The following is a description of a gene set: Human Gene Set: GOMF_RNA_POLYMERASE_II_CTD_HEPTAPEPTIDE_REPEAT_KINASE_ACTIVITY species: Homo sapiens Catalysis of the reaction: ATP + RNA polymerase II large subunit CTD heptapeptide repeat (consensus YSPTSPS) = ADP + H+ + phosphorylated RNA polymerase II., and this is the list of marker genes: CDK12, CDK9, CDK7, CCNK, MAPK1, CDK13, BRD4, DYRK1A, CDK8, CDK1